The following is a description of a gene set: Human Gene Set: OZEN_MIR125B1_TARGETS from publication Ozen M, Creighton CJ, Ozdemir M, Ittmann M (PMID 17891175) Potential targets of MIR125B1 microRNA which are up-regulated in prostate cancer. species: Homo sapiens MicroRNAs (miRNAs) are small regulatory RNAs that can regulate gene expression by binding to mRNA sequences and repressing target-gene expression post-transcriptionally, either by inhibiting translation or promoting RNA degradation. We have analysed expression of 328 known and 152 novel human miRNAs in 10 benign peripheral zone tissues and 16 prostate cancer tissues using microarrays and found widespread, but not universal, downregulation of miRNAs in clinically localized prostate cancer relative to benign peripheral zone tissue. These findings have been verified by real-time RT-PCR assays on select miRNAs, including miR-125b, miR-145 and let-7c. The downregulated miRNAs include several with proven target mRNAs whose proteins have been previously shown to be increased in prostate cancer by immunohistochemistry, including RAS, E2F3, BCL-2 and MCL-1. Using a bioinformatics approach, we have identified additional potential mRNA targets of one of the miRNAs, (miR-125b) that are upregulated in prostate cancer and confirmed increased expression of one of these targets, EIF4EBP1, in prostate cancer tissues. Our findings indicate that changes in miRNA expression may have an important role in the biology of human prostate cancer., and this is the list of marker genes: CGN, SEL1L, SAMD10, PABPC1P3, ULK3, STAT3, SMARCD2, PPAT (NCBI Gene Id 5471), SLC7A1 (NCBI Gene Id 6541), ABCC4, ATXN1, MKNK2, RNF144A, CBFB, CASC3, QSOX2, EIF4EBP1, KCNS3, PLEKHA8, LACTB, SLC7A6, TP53INP1, LYPLA2